Given this list of marker genes TARS2, TARS1, PARS2, QARS1, VARS2, AARS2, LARS1, HARS1, FARS2, AIMP1, AIMP2, LARS2, RARS1, MARS2, NARS1, FARSB, GARS1, EPRS1, IARS2, PPA2, SARS2, YARS2, IARS1, KARS1, YARS1, FARSA, DARS2, PPA1, EEF1E1, SARS1, HARS2, WARS1, MARS1, RARS2, CARS1 (cysteinyl-tRNA synthetase 1), AARS1, DARS1, CARS2, VARS1, WARS2, NARS2, EARS2, here is a description of the gene set: species: Homo sapiens tRNA Aminoacylation Human Gene Set: REACTOME_TRNA_AMINOACYLATION